The following is a description of a gene set: species: Homo sapiens The process in which the anatomical structures of a metanephric nephron tubule are generated and organized. A metanephric nephron tubule is an epithelial tube that is part of the metanephric nephron, the functional part of the metanephros. Human Gene Set: GOBP_METANEPHRIC_NEPHRON_TUBULE_MORPHOGENESIS, and this is the list of marker genes: HES1, LGR4, PKD1, SOX8, PAX2, SOX9, PAX8, HES5